Given this list of marker genes Tmem102, Bok, Ppm1k, Mpv17l, Dynlt1f, Gimap3, Them4, Slc35f6 (solute carrier family 35, member F6), Rhot1, Trp53, Bnip3l, Slc25a4, Alkbh7, Bad, Fzd9, Pmaip1, Dynlt1a, Slc25a5, Fxn, Ppif, Bnip3, Bid, Gsk3b, Nol3, Gimap5, Hip1r, Zfp13 (zinc finger protein 13), Mtch2, Gclc, Ier3, Naif1, Gsk3a, Eya2, Spg7, Chchd10, Rhot2, Siva1, Cnp, Atp5if1, Vdac2, Slc25a31, Stpg1, Hk2, Acaa2, Camk2a, Bcl2, Bcl2l2, Stat3, Mul1, Slc9a1, Tmem14a, Bcl2l1, Bax, Bcl2l11, Bak1, Atf2, Bloc1s2, Dynlt1b, Dynlt1c, here is a description of the gene set: Any process that modulates the frequency, rate or extent of the passage or uptake of molecules by the mitochondrial membrane. studied in species Mus musculus Mouse Gene Set: GOBP_REGULATION_OF_MITOCHONDRIAL_MEMBRANE_PERMEABILITY